Given this list of marker genes PDE8B, ABCC1, SLC26A4, SNAPC2, SCYL3, P2RY14, OXNAD1 (oxidoreductase NAD binding domain containing 1), MAPK9, ANXA1 (NCBI Gene Id 301), SGF29, SIGMAR1, RNF145, TMEM70, TSR2, ARID4A, TRIM7, LAMA3, BTLA, CERT1, MAP4K4, CMTM7, IRAG1, TANC1, HLA-B, ATP23, IDO1, CASQ1, HERC3, TMEM25, TNRC6A, ANPEP, IFNLR1, PANK1, AFF3, TBCA, FZD1, CHCHD6, REM1, GPI, CAPN2, FBXO10 (NCBI Gene Id 26267), PJA1, PARD6A, CLNK, SUMO3, MIS18A, SOX9, TOR1B, MBOAT1, PAWR, MYO15A, PRORP (protein only RNase P catalytic subunit), WDR76, NTAQ1, KRT33A, GULP1, XCR1, TTC8, UBXN11, TIMD4, SKAP2, AIFM2, AGPAT3 (1-acylglycerol-3-phosphate O-acyltransferase 3), FNBP1, ARHGAP5, SNX3, IMPDH2, FZD4, SMYD4, GGA1, LRBA (LPS responsive beige-like anchor protein), DUSP2, GOT2, PRR15, PACS1, NUP93, ESAM, MPPE1, AAGAB, RIOK2, CPNE3, SUPT20H, CDK14, ZNF710, FGA, ADGB, DHX35, PLCB4, SERHL2, CDC26, EML6, N4BP2, TRMT11, DYNC2LI1, ZKSCAN8, AKNA, PPAN, PTPN18, TTC9C, ZNF597, NMUR2, FNBP1L, QNG1, E2F2 (NCBI Gene Id 1870), ZNF212, SEMA4A, CEP128, COX19, C1orf198, SIRT7, POLR1A, ATP5IF1, IFT122, CDKL2, SSBP3, ELAVL4, MORN4, TRMT2B, PI4K2A, PPFIBP2, NPM1, SF3B4, EGFL8, C7orf25, CHD1L, NEK6, GINM1, STX17, RASL11B, FAM81B, TJP2, MYO1H, EFHD1, IKBKG, GTF2E1, OMA1, GDF9, GGPS1, PPP1R13B, PEX26, SNRNP200, EEF2, HLA-G, OTOF, PLCE1 (NCBI Gene Id 51196), RCHY1, RPL5, CYB5R1, TTLL4, IFT172, COMMD7, MAP3K4, UNC13D, SELENOI, UCHL5, MIS12, SLC44A1, TSNAX, WDR86, PIK3CG, DBN1, RBBP7, TRMT2A, ZNF318, POLR1C, DDX50 (DExD-box helicase 50), PIR, HLTF, NUDT14, ERC1, PSMB9, ANK1, ESYT3, FBXW5 (NCBI Gene Id 54461), SDAD1, EIF2B2, LIMK2, CLUAP1, TAFA3, MFSD14A, ZNF652, LEPROTL1, SLC31A2, PRKAB2, ABCA3, CD207, APAF1, GLTP, SELL, TXNDC15, PPT1 (palmitoyl-protein thioesterase 1), BRMS1, RNF157, SIPA1L1, KLF15 (KLF transcription factor 15), IMMP1L, CSTF2, MTNAP1, PRKRA, PPM1J, here is a description of the gene set: studied in species Homo sapiens Genes down-regulated in C57BL6 CD4 CD8 double positive thymocyte transgenic for the BDC2.5 TCR incubated with no peptide 0h versus C57BL6 CD4 CD8 double positive thymocyte transgenic for the BDC2.5 TCR incubated with mimetope negative sel 16h. Fetal thymic organ culture (FTOC) DC2.5 CD4+CD8+ thymocytes from B6g7 or NOD background. 0 or 16 hour after addition of the BDC mimitope from publication Zucchelli S, Holler P, Yamagata T, Roy M, Benoist C, Mathis D (PMID 15780994) Human Gene Set: GSE2128_CTRL_VS_MIMETOPE_NEGATIVE_SELECTION_DP_THYMOCYTE_C57BL6_DN